The following is a description of a gene set: species: Homo sapiens Any process that results in a change in state or activity of a cell or an organism (in terms of movement, secretion, enzyme production, gene expression, etc.) as a result of a hydroperoxide stimulus. Hydroperoxides are monosubstitution products of hydrogen peroxide, HOOH. Human Gene Set: GOBP_RESPONSE_TO_HYDROPEROXIDE, and this is the list of marker genes: OXR1, SIN3A, GPX1, PRKD1, RNF112, DAPK1, MT-ND1 (NCBI Gene Id 4535), CD38, CHUK, JAK2, TRPM2, PRKCD, MGST1, XRCC1, TP53INP1, SP1, APOA4, GPX3 (glutathione peroxidase 3), CD36, TMIGD1